Given this list of marker genes TBC1D3, KCNJ13, ST6GAL2, PLBD1, FAT2, MTRF1L, CBLL1 (Cbl proto-oncogene like 1), DOCK4, KIAA1549L, MAPK6, CSRNP3, TBC1D17, NPAS2, CYB561D1, BAZ1B, PTPRG, NR1D2, GGCX (NCBI Gene Id 2677), IGSF10, LRP8, WAC, PRAMEF17, TBC1D3H, ZNF213, PPP1R7, CLOCK, DLG2 (NCBI Gene Id 283225, discs large MAGUK scaffold protein 2), ZNF280B, C5AR2, AADAC, AGO1, SETD3, YPEL4, BICD2, TBC1D2, ZNF513, TRAK1, URI1, PTPN4, BCL11B, PFN2, SYT1, USH2A, ATG14, CACNA1D, DAZAP2, DLL1, PAFAH1B1, ZSWIM6, DPYSL5, ITPRID2, FEZF1, BNIP5, PAPOLB, EPHA7, ZNRF3, TENM3, NR4A2, GABBR2, TOB1, TLN2, RNF11, MCF2L, GDAP1, PAFAH1B2, PRICKLE3, DCUN1D3, here is a description of the gene set: Human Gene Set: MIR515_3P from publication Chen Y, Wang X (PMID 31504780) studied in species Homo sapiens Genes predicted to be targets of miRBase v22 microRNA hsa-miR-515-3p in miRDB v6.0 with MirTarget v4 prediction scores > 80 (high confidence targets).